Given this list of marker genes SLC25A51, CALR, MSL2, PAPSS2, KITLG, AKAP7, SOX11, MPL, MTFR1L, CA2, ACKR3 (NCBI Gene Id 57007), CWC22, METTL1, MYH7, ADRB2, AKIRIN1, DDA1 (NCBI Gene Id 79016), PHF1, HGF, PSAP, LMX1B, SPINK4, TRIM13, C19orf48P, ARID3B, RPL37A, NDUFAF4, SPSB1, CEL, RECQL, SLC6A8, POMC (proopiomelanocortin), PPFIBP2, USP34, TLE4, CCKBR, CD1D, ZBTB20, SUB1, TGIF2, DNAJA2, BPNT1, PITPNA, BRWD3, HRH2, TCF20, SCMH1, UCK1, RAPGEF4, SURF4, THYN1, ADGRL1, INSM1 (INSM transcriptional repressor 1), EML5, POLR3D (NCBI Gene Id 661), RFLNB, MEST, PEA15, RPS6KA2, CCDC152, ADGRG3, HYOU1, GREM2, STAT5A, RAD9A (RAD9 checkpoint clamp component A), ACTR1B, SLC39A4, F9, NR1D2, ARHGEF7, TMEM115, WBP1, EIF4H, USF2, NRTN, FRAT1, CANT1, SH2B3, DNAJB4, LHCGR, SLC22A1, APOBEC2, USP2, PHRF1, CHMP1B, GABRR2, DFFA (NCBI Gene Id 1676), TSG101, CD79B, EPHB2, FGD3, HCRT, STRN4, GBF1, GADD45G, REXO1, CYP3A43, MYOM2, PMPCA, USP21, SYT9, DVL1, ERCC2, TNNI2, RFX2, PCSK7, GRIA3, RETREG2, CLTB, UBE2E3, CTNNAL1, COL6A2, BLCAP, ICAM2, RAB33B, SPRYD4, MIP, ST3GAL1, HOXA3, YJU2, DUSP12, RAB17, BSDC1, SLC25A25, NECAP1, RRP9, SUMO2P7, RCVRN, NEURL4, TIMP2, CFH, SLFN12, NFIX, BTC, CELA2A, MAP1LC3A, SOX4, POLG2, SF3A2, ASGR2, CYP2E1, CRY2, APC, APP, TMEM268, SPPL2B, IGFBP1, VIP, DLX1, SEC11C, RPL12, SIAH1, SPR, KLHL21, ATP9A, TSSK2, MTREX (NCBI Gene Id 23517), EYA2, NEDD4L, COQ10A, ABCG1, AP1B1, RAE1, HES2, RALGPS2, SH3GL1, CCR9, HR, KRT7, SNX17, STK40, MYL6, ZYG11B, KRT1, LALBA, FABP7, RBM4B, TCN2, HAO2, TCEA2, TRAF2, SVIL, CREG1, SEMA4F, JARID2, NCOA3, TFPI2, BMP6, TNF, ZDHHC5, TMEM183A, AZI2, PI4K2A, PRCC, RANBP10, ZKSCAN1, MAP3K3, FBXW4, MAP4K3, PKD1, here is a description of the gene set: Human Gene Set: GSE15930_NAIVE_VS_72H_IN_VITRO_STIM_IFNAB_CD8_TCELL_UP from publication Agarwal P, Raghavan A, Nandiwada SL, Curtsinger JM, Bohjanen PR, Mueller DL, Mescher MF (PMID 19592655) Differentiation of naive CD8 T cells into cytotoxic effector cells requires three distinct signals- antigen (signal 1), costimulation -B7-1 (signal 2) and cytokine, either interleukin-12 or interferon-a/b (signal 3). Interaction of naive CD8 T cells with antigen and B7-1 programs cell division and proliferation whereas the presence of cytokines- IL-12 or IFNa/b promote survival, differentiation and memory establishment. In the absence of signal 3, the cells interacting with antigen/B7-1 undergo tolerance induction. The objective of this study was to elucidate the mechanisms how the provision of signal 3 promotes differentiation and averts tolerance induction in CD8 T cells. Trichostatin A is a pharmacological agent that inhibits histone deacetylase activity, hence regulating chromatin structure and gene expression and differentiation in many cell types. Gene signature profiles of IL-12, IFNa/b and trichostatin A stimulated cells were compared to elucidate the molecular mechanisms of gene regulation. Oligonucleotide microarray analysis is carried out to determine the extent and molecular nature of the CD8 T cell differentiation program induced by IL-12 or IFNa/b in concert with antigen and B7-1 signal. studied in species Homo sapiens Genes up-regulated in comparison of CD8 T cells at 0 h versus those at 72 h after stimulation with antigen-B7-1.